Given this list of marker genes Pax6, Fezf2, Bcl11b, Tbr1, Gata2, Ascl1, here is a description of the gene set: species: Mus musculus Mouse Gene Set: GOBP_COMMITMENT_OF_NEURONAL_CELL_TO_SPECIFIC_NEURON_TYPE_IN_FOREBRAIN The commitment of neuronal precursor cells to become specialized types of neurons in the forebrain.